Given this list of marker genes SOAT2, SQLE, ZFPM1, CLDND2, RASD2, DPY19L1, ZBTB38, ZBTB32, NRP1, CACNG8, UPB1, SELENON, SDHA, RAB11FIP4, KRT5 (NCBI Gene Id 3852), PLXDC2, ELMO2, PTPN13, RAB15, LPIN2, SDC2, CATSPER4, KCNQ5, ONECUT2, EHD1, AMMECR1, TM7SF3, MUC20, C1QTNF6, MRPS22, SVOP, SH3RF2, ATP5F1B, DLAT, GATA3, KLRG1, ANXA1, TWIST1, FGL2, PLEK, UCK2, DCLRE1A, PKIG, TRIM42, COBLL1, ACLY, IPO5, ANKRD55, CLEC4G, TTC39C, FGR, NAIF1, COL12A1, GPC1, NEFH, SELENOI, PPFIBP2, CCNH, RXRA, PDSS1, LPCAT4, TFDP1, CHPT1, APLF, B4GALT5, AK1, ZEB2, MYO6, ARHGAP18, PPM1G, ACOXL, MCU, NUP93, SLC25A13, PLAT, GZMA, DENR (NCBI Gene Id 8562), RGS16, SHC1, HRH4, ITGB1, MCOLN3, CNIH2, WNT5B, ACACA, STAU2, PLXNC1, CYP11A1, CHST2, GNPTAB, CBR3, H2AZ1, IL10RA (interleukin 10 receptor subunit alpha), KLRK1, EPAS1, TNFSF10, CCDC50, BCO2, GPM6B, RAD54L2, IGF2BP3, RAN, IL4, RTN2, DAB2IP, EHD2, ELFN2, ENTPD1, CCN4, LIG1, ANKRD42, PTCH1, CARMIL1, ZFAND4, RBM47, GBP6, IDE, H2BC14, TADA3, SCO1, MDM2, ESYT1, MGAT1, MYL4, CS, PPP3CA, CDC42EP3, NEDD4, AKAP1, HS6ST2 (heparan sulfate 6-O-sulfotransferase 2), GOT2, MCM5, NINJ2, SLC35F2, SV2C, LRP11, LRBA, CDKN2A, P2RY12, XK, DCLRE1B, SEMA6D, VCAN, MLKL, ATP2A2, INTS4, PSMA5, GAS7, MYH1, YBX3, THEMIS, MBOAT7, CEP104, SLC25A53 (solute carrier family 25 member 53), PRR19, EFR3B, DIXDC1, KCNA7, POLM, SPRED2, ACSF3, ITGA1, ALG10B, CABP4, KCNK6 (NCBI Gene Id 9424), RNASEH2B, EPHA7, here is a description of the gene set: Human Gene Set: GSE3920_IFNA_VS_IFNG_TREATED_ENDOTHELIAL_CELL_DN species: Homo sapiens Genes down-regulated in endothelial cells: interferon alpha versus IFNG. from publication Indraccolo S, Pfeffer U, Minuzzo S, Esposito G, Roni V, Mandruzzato S, Ferrari N, Anfosso L, Dell'Eva R, Noonan DM, Chieco-Bianchi L, Albini A, Amadori A (PMID 17202376) IFNs are highly pleiotropic cytokines also endowed with marked anti-angiogenic activity. In this study, the mRNA expression profiles of endothelial cells (EC) exposed in vitro to IFN-alpha, IFN-beta, or IFN-gamma were determined. We found that in HUVEC as well as in other EC types genes were upregulated (>2-fold increase) by IFNs, including genes involved in the host response to RNA viruses, inflammation, and apoptosis. Interestingly, genes showed a >5-fold higher induction by IFN-alpha in EC compared to human fibroblasts; among them, the gene encoding the angiostatic chemokine CXCL11 was selectively induced by IFN-alpha in EC along with other genes associated with angiogenesis regulation, including CXCL10, TRAIL, and guanylate binding protein 1 (GBP-1). These transcriptional changes were confirmed and extended by quantitative PCR analysis and ELISA; whereas IFN-alpha and IFN-beta exerted virtually identical effects on transcriptome modulation, a differential gene regulation by type I and type II IFN emerged, especially as far as quantitative aspects were concerned. In vivo, IFN-alpha-producing tumors over-expressed murine CXCL10-11, GBP-1 and TRAIL, with evidence of CXCL11 production by tumor-associated EC. Overall, these findings improve our understanding of the anti-angiogenic effects of IFNs by showing that these cytokines trigger an anti-angiogenic transcriptional program in EC. Moreover, we suggest that quantitative differences in the magnitude of the transcriptional activation of IFNresponsive genes could form the basis for cell-specific transcriptional signatures.